The following is a description of a gene set: studied in species Homo sapiens The chemical reactions and pathways by which an unsaturated fatty acid (such as arachidonic acid or linolenic acid) is converted to other compounds, and in which the first step is hydroperoxide formation catalyzed by lipoxygenase. Human Gene Set: GOBP_LIPOXYGENASE_PATHWAY, and this is the list of marker genes: ALOX5, ALOX15, ALOX12B, GPX4, HPGD, PLA2G3, ALOX15B, ALOX12, ALOXE3, PTGS2, GPX1